Given this list of marker genes CALCA, TLK1, CYP7A1, GRIA2, ST3GAL1 (ST3 beta-galactoside alpha-2,3-sialyltransferase 1), GPAT2, HNRNPC, MAN1A1, PPP3R1, TMEM44, NKAPD1, CAMK1D, WNT10A, ANKRD45, BAZ2A, TAFA2, SPMAP1, CCDC191, PEX11A, RPL36A, CABLES1, ZNF691, CES4A, APTX, GNAS, RC3H1, DDX52, DNAJC7, TNFSF8, AQP10, SLC48A1, EPHA4, TMEM68, TLR10, TAGLN2, CCL11, UBE2L6, SPSB3, ING4, DDX27, GAREM1, CTSK, VAMP2, SGCD, GTDC1, KRIT1, PAK2, PPP4R3A, VEZF1, PPARG, KIF3C, NPEPPS, EMP2, CWC25, NSD3, C20orf96, TTLL6, PRSS33, MBIP, PPP1R12B, PBX3, ZNRF1, AKAP6, CPEB2, PINX1, TRPS1, TBX4, AAK1, PIANP, GML, RNASEH2C, MAX, CECR2, CACNA1C, GORASP1, GLO1, SUMO2, GCDH, SRFBP1, PPP2R5D, JPH2, MAOA, ZSWIM4, SRSF1, XKR6, RIMS4, UCHL1, SLC25A2, DCTN4, CEP170, ZSWIM6, RGS21, TERF2, BEND3, GANAB, TMEM80, ZBED4, TFCP2L1, CREB5, MEAF6 (MYST/Esa1 associated factor 6), SLITRK2, IKBKG, SMIM20, ARRB2, SPRR2G, PTPMT1, FGB, SH3PXD2A, KALRN, PPM1E, ZNF425, DCX, UNC5CL, PPP2CB (protein phosphatase 2 catalytic subunit beta), GLIPR1L2, CDK5RAP2, ITPK1, SNX27, NAAA, GRIN2B, CD164L2, KDM5B, POLDIP3, NDUFAF5, FCHSD1, MED26, DPF2 (double PHD fingers 2), POU3F4, BOD1L2, DOCK9, ZNF559-ZNF177, DNAJC18, MCFD2 (multiple coagulation factor deficiency 2, ER cargo receptor complex subunit), FKBP4, NFE2, DIRC1, STK10, DLGAP4, TACR1, BCAN, PGAM1, FAM76A (family with sequence similarity 76 member A), PRIM2, PARP9, PRELID3A, RAB6A, SLC25A15, APBB1, TYRP1, ZEB1, NINJ2, SUPT3H, GAS7, C2orf49, TNFSF18, ERAP1 (NCBI Gene Id 51752), CYP7B1, here is a description of the gene set: studied in species Homo sapiens Genes predicted to be targets of miRBase v22 microRNA hsa-miR-7515 in miRDB v6.0 with MirTarget v4 prediction scores > 80 (high confidence targets). from publication Chen Y, Wang X (PMID 31504780) Human Gene Set: MIR7515